Given this list of marker genes GPC1, SULT1C2, HS6ST1, PDHB, B3GAT1, PGK1, TPK1, CHST12, DLST, ACSF3, MPST, ACSL5, CHST11, ACSBG2, SULT1A3, PAPSS2, B3GAT3, AKR1A1, MGST2, IDUA, HS3ST3A1, ACLY, TST, CSGALNACT1, SULT2A1, DSEL, FMO3, G6PD, AAAS, DIP2A, HEXB, GGTA1, ABHD14B, GCLC, NUDT7, B3GAT2, DLD, CSAD, MTRR, CHSY1, MTHFD1, CHST5, GLYAT, CHST2, CBS, GPX1, GGTLC3, ELOVL3, MMUT, SQOR, GCDH, ACSS2, PPT1, GSTA4, ELOVL6, MIR21, NDST1, ACOT9 (NCBI Gene Id 23597), NUDT19, EXTL1, ARL6IP5, B3GALT6, PPCS, CHPF, ACSM2A, CHPF2, SULT1C3, PDK3, DGAT1, FMO1, PDK4 (pyruvate dehydrogenase kinase 4), GSTO1, ENPP1, HS6ST2, OXSM, HACD1, SUCLA2, SLC1A2, ACOT4, BPNT1, PAPSS1, MVK (mevalonate kinase), AASS, STAT5A, PANK1, BTD, CYTL1, ELOVL7, MLYCD, ACSM1, GAL3ST4, HTD2, MCCC1, GSTA3, GSTZ1, CHST8, MCCC2 (NCBI Gene Id 64087), PPCDC, SULT1B1, GPAT4, NFE2L2, SLC25A10, CHSY3, GGT3P, MICAL2, TPST1, TM9SF2, GSTA1, BHMT2, GSTP1, HAGH, CHAC2, XYLT2, GGT7 (gamma-glutamyltransferase 7), AHCY, GLO1, ELOVL1, ACSL1, OPLAH, FAR1, TCF7L2, DCAKD, ACSM4, SLC35B2, PXYLP1, MPC2, GAL3ST3, BHMT, ADI1, GSR, HPGDS, ACSM5, HYAL1, CHST4, PTER, MMACHC, GSTO2, MAT2B, THTPA, DPEP2, HS3ST6, GLCE, GGT5, HMGCS2, GPAM, GNS, OGDH, ACSS1, HSD17B12, GSTK1, PDHA2, AHCYL1, METTL16, HSD17B4, CHST3, PPT2, ACSBG1, STAT5B, XYLT1, ENSG00000274276, DLAT, ARSG, MCEE, CTNNB1, GSTM5, SUCLG2, SULT1E1, NDST4, GGTLC2, ACOT1, EXT2, SULT1A4, ACSM3, SLC35D2, GSTA5, HS3ST3B1, GHR, CTNS, TECR, SOD2 (superoxide dismutase 2), HS3ST5, TDO2, MTR, THEM5, SLC19A2, HS3ST2, GSTM2, CDO1, CSGALNACT2, HS2ST1, GGT6, SNCA, ACSL3, SLC19A3, PDHX, CROT, GGT1, MSRA, HPSE, NDST2, TKTL1 (NCBI Gene Id 8277), UGDH, ACP3, HACD2, ACOT12, SP1, NUDT8, CBR4 (NCBI Gene Id 84869), GLRX2, SULT1A1, APIP, PDK1, ACSL6, AADAT, CHST6, EXTL2, NAT8, GSTA2, ACSM6, NDST3, SOD1, SLC25A19, GLB1, CHST9, GSTM4, SULT1A2, FASN, GNMT, ACSL4, HS6ST3, SUCLG1, GSS, IDH1, CHAC1 (ChaC glutathione specific gamma-glutamylcyclotransferase 1), CHST1, FAR2, SMS, PHGDH, ACSM2B, ACOT7, LIAS, ACSF2, CPS1 (carbamoyl-phosphate synthase 1), ACACA, ACOT11, HS3ST1, GGT2P, SULT2B1, HLCS, LPO, HYAL4, VANGL2, TPST2, BLMH, SLC27A2, BPHL, BAAT, CHST7, MAT2A, MAT1A, HMGCS1, PIPOX, AGXT, COASY, PANK2, GSTM3, PANK4, ACOT6, SLC5A6, SLC7A11, MVD, GSTT2, DSE, ACOT8, VNN1, HMGCR, MTHFR, ICMT, ACAT1, ETHE1, GUSB, HS3ST4, EXTL3, ELOVL2, MICAL1, DPEP1, BCKDK, GSTT2B, GCLM, IDS, GSTT4, FITM2, SULF1, GSTM1, DGAT2, NOX4, SUOX, SLC1A1, CHST13, SULF2, NAGLU, ACOT2, HGSNAT, SULT1C4 (sulfotransferase family 1C member 4), EXT1, SULT4A1, ABCD1, ELOVL5, SGSH, NDP, PMVK, SULT6B1 (NCBI Gene Id 391365), ELOVL4, GSTT1, TSTD1, PANK3, IGF1, ENSG00000293349, PDHA1, ENOPH1, CTH, AHCYL2, GGTLC1, NFE2L1, PDK2, ACACB, here is a description of the gene set: The chemical reactions and pathways involving the nonmetallic element sulfur or compounds that contain sulfur, such as the amino acids methionine and cysteine or the tripeptide glutathione. studied in species Homo sapiens Human Gene Set: GOBP_SULFUR_COMPOUND_METABOLIC_PROCESS